Given this list of marker genes Tnfrsf1a, Smpd2, Tnf, Rack1, here is a description of the gene set: electronically inferred by orthology from the curated human pathway part of: TNF signaling species: Mus musculus This event has been computationally inferred from an event that has been demonstrated in another species.<p>The inference is based on the homology mapping from PANTHER. Briefly, reactions for which all involved PhysicalEntities (in input, output and catalyst) have a mapped orthologue/paralogue (for complexes at least 75% of components must have a mapping) are inferred to the other species. Reactome Pathway: TNFR1-mediated ceramide production